Given this list of marker genes Abhd10, Fuca1, Fuca2, Gba2, Naga, Gba1, Gla, here is a description of the gene set: Mouse Gene Set: GOBP_GLYCOSIDE_CATABOLIC_PROCESS The chemical reactions and pathways resulting in the breakdown of glycosides, compounds in which a glycosyl group is substituted into a hydroxyl, thiol or selenol group in another compound. studied in species Mus musculus